Given this list of marker genes Oas1g, Oas1a, Oas1h, Oas1e, Oas1f, Oas1b, Pde3a, Oas3, Oas1c, Oas1d, Npm1, Tmbim6, here is a description of the gene set: Any process that modulates the rate, frequency, or extent of ribonuclease activity, catalysis of the hydrolysis of phosphodiester bonds in chains of RNA. Mouse Gene Set: GOBP_REGULATION_OF_RIBONUCLEASE_ACTIVITY studied in species Mus musculus